Given this list of marker genes Mstn, Gstp1, Ppard, Nfe2l2, Egr1, Itgb1bp1, P2ry6, Lpar1, Adamts1, Ptger4, Rhoa, Src, Parva, Arpc2, Tpm1, Igfbp5, Slit2, Itga2, Gna12 (guanine nucleotide binding protein, alpha 12), Drd4, Mir124a-1hg, Net1 (NCBI Gene Id 78563), Ddr1, Zfp950, Ptpn1, Rock1, Six1, P2ry2, Megf10, Smo, Pak1, Crk, Ilk, Trib1, Pcsk5, Atp7a, Met, Stat5b, Adipoq, Enpp1, Cav1, Retn, Itga4, Mmp1a, Ccl5 (NCBI Gene Id 20304), Rps6kb1, Pde4d, Mdk, Postn, Sorl1, Gna13, Tlr4, Pgr, Apex1, Myc, Tmsb4x, Nf1, Dock5, Xbp1, S100a11-ps, Bmpr1a, S1pr2, Hdac4, Nox4, Anxa1, S100a11, Rapgef4, Plat, Grb10, Park7, F3, Nrp1, Fga, Arpc5, Pdgfb (NCBI Gene Id 18591), Gstp2, Ager, Plxna1, Tert, Ccn3, Naca, Ddr2, Pparg, Il6st (NCBI Gene Id 71317), Igfbp3, Nr4a3, Has2, Tacr1, Coro1b, Rapgef3, Ddit3, Myo5a, Plekho1, Map3k7, Lrp1, Camk2d (NCBI Gene Id 77170), Foxo4, Bin3, Il18, Pdgfrb, Ndrg4, Myh9, Dock4, Six4, Tcp11l2, Aif1 (allograft inflammatory factor 1), Ace, Pdgfd, Bcl2, Vtn, Sema6d, Nox1, Pax3, Ssh1, Iqgap1, Dock7, Akirin1, Cyp1b1, Plau, Agt, Mef2c, Egfl7, Pdgfa, Fat1, Mir504, Ppargc1a (NCBI Gene Id 320239), Tafa5, Fgf9, Serpine1, Myocd, Igf1, Ptk2, Ccn4, Mdm2, Prkg1, Kcnn4, Abhd2, Itgb3, Thbs4, here is a description of the gene set: Mouse Gene Set: GOBP_MUSCLE_CELL_MIGRATION The orderly movement of a muscle cell from one site to another, often during the development of a multicellular organism. studied in species Mus musculus